Given this list of marker genes ARHGEF26, ITSN1, ARHGEF5, BEX3 (NCBI Gene Id 27018), APH1A (aph-1 homolog A, gamma-secretase subunit), ARHGEF37, ECT2, ARHGEF15, TIAM1, TRIO, APH1B (aph-1 homolog B, gamma-secretase subunit), ARHGEF38, YWHAE, VAV3, BCL2L11, ARHGEF17, TRAF6, NGFR, ARHGEF16, NCSTN, ARHGEF33, ARHGEF2, SQSTM1 (sequestosome 1), ARHGEF3, ARHGEF6, SOS2, CASP3, ARHGEF40, AATF, ITGB3BP, NET1, FGD2, GNA13, RPS27A, RAC1, AKAP13, ARHGEF10L, ARHGEF10, FGD1, UBC, RASGRF2, ARHGEF19, ARHGEF4, KALRN, MCF2L, BAD, NGEF, PLEKHG5, ARHGEF1, VAV2, ABR (NCBI Gene Id 82701), PSEN1, PSEN2, CASP2, FGD3, MAPK8, TIAM2, ARHGEF35, ARHGEF11, UBB, SOS1, ARHGEF7, MCF2, PREX1, ARHGEF39, OBSCN (NCBI Gene Id 84033), ARHGEF9, VAV1, MAGED1, ARHGEF18, PSENEN, FGD4, ARHGEF12, UBA52, NGF, PLEKHG2, here is a description of the gene set: Human Gene Set: REACTOME_CELL_DEATH_SIGNALLING_VIA_NRAGE_NRIF_AND_NADE Cell death signalling via NRAGE, NRIF and NADE species: Homo sapiens